The following is a description of a gene set: Human Gene Set: HP_MENINGOENCEPHALOCELE Meningoencephalocele species: Homo sapiens, and this is the list of marker genes: POMT1, FKRP, FKTN, POMT2, LARGE1